Given this list of marker genes POGLUT1, PTEN (phosphatase and tensin homolog), PSENEN (presenilin enhancer, gamma-secretase subunit), HEPACAM, KRT5, POFUT1, here is a description of the gene set: Penile freckling Multiple pigmented macules located on the skin of the penis. Human Gene Set: HP_PENILE_FRECKLING studied in species Homo sapiens